Given this list of marker genes Clec4f (C-type lectin domain family 4, member f), Mbl2 (mannose-binding lectin (protein C) 2), Lgals1, Eng, Galk1, here is a description of the gene set: studied in species Mus musculus Mouse Gene Set: GOMF_GALACTOSE_BINDING Binding to aldohexose galactose (galacto-hexose), a common constituent of many oligo- and polysaccharides.